The following is a description of a gene set: Mouse Gene Set: GOCC_SAM_COMPLEX A large complex of the mitochondrial outer membrane that mediates sorting of some imported proteins to the outer membrane and their assembly in the membrane; functions after import of incoming proteins by the mitochondrial outer membrane translocase complex. studied in species Mus musculus, and this is the list of marker genes: Dnajc11, Samm50, Mtx3, Mtx1, Mtx2